Given this list of marker genes GBA3, LCT, GALC, GBA1, GBA2, here is a description of the gene set: Catalysis of the reaction: glycosyl-N-acylsphingosine + H2O = a sugar + N-acylsphingosine. species: Homo sapiens Human Gene Set: GOMF_GLYCOSYLCERAMIDASE_ACTIVITY